Given this list of marker genes MRPL47, MRPL46, MRPS14, MRPS5, MRPS11, MRPL43, MRPL45, MRPL32, MRPL57, MRPL27, MRPL9, MRPS18C, MRPS30, MRPL44, MRPL20, MRPL36, MRPS15, DAP3, MRPL4, MRPL23, MRPS9, MRPL15, MRPL11, CHCHD1, MRPS2, MRPL14, MRPL16, GADD45GIP1, MRPL28, MRPS35, MRPS28, MRPS6, MRPL22, MRPS24, MRPL39, MRPS22, MRPL18, MRPL50, MRPS10, MRPL21, MRPS33, MRPS21, MRPL19, PTCD3, MRPL37, MRPL41, MRPL42, MRPS7, MRPL53, MTG2, MRPL40, MRPL17, MRPS25, MRPL34 (NCBI Gene Id 65994), MRPL12, MRPL38, MRPL3, MTG1, MRPL49, MTERF4, NSUN4, MRPL54, MRPL48, MRPL35, MRPL52, MRPL58, MRPL24, MRPL13, MRPS34, MRPS23, MRPL30, MRPS26, MRPS31, MRPS17, MRPL33, MRPS18B, MRPL2 (NCBI Gene Id 65007), NSUN3, MRPL55, MRPL51, MRPS16, MRPS27, MRPL1, MRPS12 (mitochondrial ribosomal protein S12), MRPL10, AURKAIP1, MRPS18A, here is a description of the gene set: Human Gene Set: GOCC_ORGANELLAR_RIBOSOME A ribosome contained within a subcellular membrane-bounded organelle. studied in species Homo sapiens